The following is a description of a gene set: Human Gene Set: GOBP_DOUBLE_STRAND_BREAK_REPAIR_VIA_BREAK_INDUCED_REPLICATION species: Homo sapiens The error-free repair of a double-strand break in DNA in which the centromere-proximal end of a broken chromosome searches for a homologous region in an intact chromosome. DNA synthesis initiates from the 3' end of the invading DNA strand, using the intact chromosome as the template, and progresses to the end of the chromosome., and this is the list of marker genes: GINS2, MCM2, MCM4, MCMDC2, CDC7, CDC45, MCM3, MUS81, MCM6, MCM5, GINS4, MCM7